The following is a description of a gene set: Neighborhood of PTPN9 Neighborhood of PTPN9 protein tyrosine phosphatase, non-receptor type 9 in the MORF expression compendium Human Gene Set: MORF_PTPN9 studied in species Homo sapiens, and this is the list of marker genes: PSD4, FKBP15, NUDT3, TPMT, DGCR11, CNOT4, ANKRD12, RPA2, MVK (NCBI Gene Id 4598), ACR, B4GALT3, GSK3A, TCOF1, M6PR, PFDN1, TSPO2, PAIP2B, NHERF2, EML3, PAX8, CNP, TAFAZZIN, RXRB, CNTN1, TMEM94, ORC1, PCBP3, RBM8A, GHITM, HSF4, IGSF9B, PTPN9, KHNYN, USP19, DDX11, ODF1, PRPH, SLC22A24, CASP2, PML, IFT140, IGHMBP2, GPR35, MOK, ZBED1, FDXR, IKBKG, CAMK2B, MGAT1, DRG2, SLC12A4, SLC6A9, ADAM15, ADAMTSL2, HMGXB3, NDST1, ENTREP3, MYL2, PITPNM1, LINC00928, TUB